Given this list of marker genes C9, C4B, CFH, GBP1, GBP5, here is a description of the gene set: species: Homo sapiens Human Gene Set: GOCC_OTHER_ORGANISM_PART Any constituent part of a secondary organism with which the first organism is interacting.